The following is a description of a gene set: species: Mus musculus Mouse Gene Set: GOBP_ESTABLISHMENT_OF_EPITHELIAL_CELL_APICAL_BASAL_POLARITY The specification and formation of the apicobasal polarity of an epithelial cell., and this is the list of marker genes: Nherf1, Msn (NCBI Gene Id 97596), Fat1, Wnt5a, Tcf15, Spag6l (sperm associated antigen 6-like), Cdc42, Sh3bp1, Ophn1, Ttc8, Myo9a, Camsap3, Rhoa, Crb3, Syne4, Lama1, Ptk7, Ift20, Foxf1